The following is a description of a gene set: Testicular germ cell cancers remain one of the few solid tumors routinely cured in advanced stages with conventional cisplatin-based chemotherapy. The mechanisms remain largely unknown. Through use of gene-expression array profiling we define immediate transcriptional targets in response to cisplatin in testicular germ cell-derived human embryonal carcinoma cells. We report genes upregulated and five genes repressed by cisplatin. Several of these gene products, including FAS, TRAILR3, PHLDA3, LRDD, and IER3 are previously implicated in the apoptotic death receptor pathway, while others including SESN1, FDXR, PLK3, and DDIT4 are known mediators of reactive oxygen species generation. Approximately 54% of the upregulated genes are established or suspected downstream targets of p53. Specific siRNA to p53 prevents cisplatin-mediated activation of p53 and p53 pathway genes and renders embryonal carcinoma cells relatively resistant to cisplatin cytotoxicity. Interestingly, in p53 knockdown cells nearly the entire set of identified cisplatin targets fail to respond or have a diminished response to cisplatin, suggesting that many are new direct or indirect targets of p53 including GPR87, STK17A, INPP5D, FLJ11259, and EPS8L2. The data indicate that robust transcriptional activation of p53 is linked to the known hypersensitivity of testicular germ cell tumors to chemotherapy. Many of the gene products may participate in the unique curability of this disease. from publication Kerley-Hamilton JS, Pike AM, Li N, DiRenzo J, Spinella MJ (PMID 15940259) Human Gene Set: KERLEY_RESPONSE_TO_CISPLATIN_DN species: Homo sapiens Genes genes down-regulated in NT2/D1 cells (embryonal carcinoma) in response to treatment with cisplatin., and this is the list of marker genes: HESX1, MYC, CYP26A1, LPIN1, HMGCS1